The following is a description of a gene set: species: Homo sapiens Pathway Definition from KEGG: POLB == (POLD,POLE) == PCNA == RFC -> PCNA+FEN1 -> PCNA+LIG1 Long patch BER. Pathway ID: N01436. Pathway type: Reference. Pathway class: nt06504 Base excision repair. Human Gene Set: KEGG_MEDICUS_REFERENCE_LONG_PATCH_BER, and this is the list of marker genes: LIG1, POLD1, POLD3, FEN1, POLD4, POLE2, RFC4, POLE4, RFC2, POLB, PCNA, POLD2, RFC3, POLE (NCBI Gene Id 80252), RFC5, RFC1, POLE3